Given this list of marker genes Agt (NCBI Gene Id 11606), Smpd3, Edn1, Cacna1g, Ednra, Edn2, Mylk, Nmu, Cd38 (NCBI Gene Id 12494), Mkks, Grip2, Scnn1b, Bbs2, Htr2a, here is a description of the gene set: Mouse Gene Set: GOBP_TONIC_SMOOTH_MUSCLE_CONTRACTION A process in which force is generated within tonic smooth muscle tissue, resulting in a change in muscle geometry. Force generation involves a chemo-mechanical energy conversion step that is carried out by the actin/myosin complex activity, which generates force through ATP hydrolysis. In the tonic smooth muscle, the muscle contraction occurs without an ordered sarcomeric structure. Tonic smooth muscle contraction occurs as a sustained continuous contraction. species: Mus musculus